Given this list of marker genes MFAP4, FBLN5, ELN, EFEMP2, FBLN1, here is a description of the gene set: species: Homo sapiens An supramolecular fiber that consists of an insoluble core of polymerized tropoelastin monomers and a surrounding mantle of microfibrils. Elastic fibers provide elasticity and recoiling to tissues and organs, and maintain structural integrity against mechanical strain. Human Gene Set: GOCC_ELASTIC_FIBER